Given this list of marker genes RIPK2, CD3E, PRKCQ, CARD11, TGFBR2, LGALS9, CD55, CD28, CD81, XCL1, here is a description of the gene set: Human Gene Set: GOBP_POSITIVE_REGULATION_OF_CD4_POSITIVE_ALPHA_BETA_T_CELL_PROLIFERATION species: Homo sapiens Any process that activates or increases the frequency, rate or extent of CD4-positive, alpha-beta T cell proliferation.